The following is a description of a gene set: The aim of this dataset was to study in detail the transcription kinetics initiated by cytokine IL-4 in early differentiation of Th2 cells. Genes up-regulated in comparison of untreated CD4 T cells at 0 h versus the untreated cells at 0.5 h. species: Homo sapiens from publication Elo LL, Järvenpää H, Tuomela S, Raghav S, Ahlfors H, Laurila K, Gupta B, Lund RJ, Tahvanainen J, Hawkins RD, Oresic M, Lähdesmäki H, Rasool O, Rao KV, Aittokallio T, Lahesmaa R (PMID 20620947) Human Gene Set: GSE17974_0H_VS_0.5H_IN_VITRO_ACT_CD4_TCELL_UP, and this is the list of marker genes: DTHD1, PGAP3, GSPT2, CFLAR-AS1 (NCBI Gene Id 65072), ARIH2OS, ZFYVE28, GABRB1, FCGR1BP, CEP170B, TENM1, SCGB3A1, DPEP1, COL2A1, LINC00173, GJC2, PITPNA, IL17RE, GABBR1, SETX, LDHAL6B (NCBI Gene Id 92483), GAL3ST4, TTLL12, CHRNA3, KNG1, IGSF21, CTDSPL, RPS6KL1, ILK, SYNGAP1, BAAT, CLEC7A, AMOT, APOBEC3A, SMARCC2 (SWI/SNF related, matrix associated, actin dependent regulator of chromatin subfamily c member 2), MMAB, ZNF75D, G0S2, LMNTD2, TAF13, ADAM20 (NCBI Gene Id 8748), MATK, PDE4DIP, SNUPN, LRRC61, ZNF337, TMED3, CXXC5 (NCBI Gene Id 51523), LILRB2, PRL, ASL, SLC25A23, GBP5, SPMIP8, NCF1C, UBL7, SUSD4, CCDC116, ATP6AP1L, YIPF2, UQCC3, SALL2, PPM1G, HCK, IL36RN, ADCYAP1R1 (ADCYAP receptor type I), ZNF688, BANF2, MCOLN1, LILRB1 (NCBI Gene Id 23445), ZNF625, CCDC83, BPNT1, TRPA1, GRM2, FSTL4, CLDN15 (NCBI Gene Id 245814), EMC9, AHSG, TFAP2C, JOSD2, FLAD1, UBXN8, LMF2 (lipase maturation factor 2), ACTL7A, SPINK7, NDOR1, PTPRCAP, TADA3, SDR9C7, IQUB, ST6GALNAC5, MECOM, FANCC, DDR1, SCN8A, FGR, NCKIPSD, PPP1R1B, WNK3, RTP5, SLC7A11, TM4SF18, MMP1, NUDT18, LINC00112, NME6, NSUN5P2, ZNF792, CD22, CLIP2, KAT8, TREM1, ABCC8, KLB (NCBI Gene Id 152831), MTARC1, TAAR1, OGFOD1, PCYT1B, LINC00309, FAAP20, TCAP, RPL23AP7, SNX17, PDGFRL, CHP1, ING4, ZBTB45, OSBPL7, TBX5-AS1, SIGLEC15, KCNQ3, PPIAL4A, TRIP10, CASP4LP, PML, DNAH5, ARSA, H2AC16, LDB2, SUSD3, ZDHHC11, SAMD10, ERVW-1, NUDT22 (nudix hydrolase 22), SP140, IL17RC, PCIF1, ZCCHC4, PP12613, CCKBR, C4BPA, SH2D6, ATP1A1-AS1, HAAO, GLYCTK, CORIN, SASH3, CYB561D1, CEPT1, MECR (NCBI Gene Id 554211), STK16, NKX6-2, ASB16-AS1, RIPPLY1, SEPTIN1, CMA1, KXD1, ENSG00000240207, NXF5, IFI30, NELL1, SLC7A7, CCDC13-AS1, ARMC2, SERPING1, ALG12, DLX4, ZNF319, EIF4ENIF1, COQ4 (NCBI Gene Id 51117), TARS2, ZNF731P, MAP2, AGPAT1, MAGI1-IT1, SYCP2L, PGC, TGFB3, TFPT, AHDC1, DDA1, ANKLE1, ZNF670, CD14, C1orf159